The following is a description of a gene set: The presence of excess amniotic fluid in the uterus during pregnancy. Human Gene Set: HP_POLYHYDRAMNIOS studied in species Homo sapiens Polyhydramnios, and this is the list of marker genes: SNRPB, TRAIP, TBCD, TP63, KBTBD13, IBA57, VAC14, NRCAM, ADAT3, B3GLCT, COL13A1, HACD1, ERBB2, ZMPSTE24, LBR, SCN4A, SYNE1, MAMLD1, WNT3, TPM2, DIS3L2, EGFR, RPL10, SIN3A, ADARB1, KRAS, MAGEL2 (NCBI Gene Id 54551), CREBBP, CLCN7, RERE, ATP6V0A1, SLC5A7 (solute carrier family 5 member 7), DPM2, TBC1D24, NRTN, DYRK1A, SCYL2, GBA1, MYH11, ASCC1, KCNJ6, CHD7, COASY, SPRED2, NRAS (NRAS proto-oncogene, GTPase), ABCD1, RPL11, ALDH1A2, KDM3B, PIGN, MYO9A, MADD, SELENON, ACTA1, HSD17B4, UFD1, SLC35D1 (NCBI Gene Id 23169), HYLS1, CCDC47, SLC18A3, RAB34, CHRNA1, SCN8A, SLC27A4, TSEN2, PHACTR1, SHOC2, BUB3 (NCBI Gene Id 9184), MYH3, CRB2, PIGQ (phosphatidylinositol glycan anchor biosynthesis class Q), FIG4, TFAM, RREB1, GPC4, FUT8, PWAR1, HRAS, WBP4, TBCK, JMJD1C, ZC4H2, TRIP11, CRELD1, ITGB4, CLPB, INPPL1 (inositol polyphosphate phosphatase like 1), CDC42BPB, ARVCF, MTM1 (myotubularin 1), AKT2, FKBP14, SLC2A1 (solute carrier family 2 member 1), TMCO1, NPAP1, DPF2, AMMECR1, MTHFR, MDFIC, CHD8, RYR1, MYLK, ERBB3, TAPT1, COL2A1, ODC1, FGFR2, TRIP13, ESCO2, SLC25A26, PWRN1, EBP, PRMT7, DMPK, SOX17, NPHP3, AVPR2 (arginine vasopressin receptor 2), FGFR3, MAP2K2, IRF6, ASCL1, RET, MYOD1, PCGF2, RSPO2, SNAP25, YWHAE, MSX1, KIF7, CILK1, LMNA, TTC7A, BUB1, DOK7, DYNC2LI1, AGRN, FOXE1, SLC25A1, PPP1R13L, ADAMTS3, SMG9, MOGS, MTMR14, ATP7A, B3GALT6, GBE1, ATP1A2, RTL1 (NCBI Gene Id 651665), SLC25A46, ZBTB42, PTH1R, DYNC2I2, NEB, NPC2, SLC9A3, MUSK, CHRND, FANCB, CFL2, RHD, FLNB, LMOD3, SOD1, TSEN54, PI4KA, DLK1, ENPP1, KIF21A, ASXL1, MYCN, CBL, MAFB, ACTG2, SNORD115-1, TPM3, GLE1, BSND, HIRA, ZFX, PPP1CB, KLHL40, SKIC3, KIAA0586, GLDN, CDK13, BIN1, PIEZO1, NECTIN1, MEG3, CHRNG, VANGL2, SEMA3E, IPO8, CHAT, EDNRB, LONP1, ALG9, RMND1, VAMP1, OFD1, IFT56, RRAS2, ANO1, SLC16A2, HBA1, FANCF, SMO, SEMA3C, MKRN3, ABCC6, PAICS, ZNF699, SPINT2, KAT6B, HBA2, BRAF, DYNC2I1, PLEC, DNM2, MAGED2, PLAA, ERF, NUP88, EDN3, DPH5, GPC3, WDR81, ALPL (NCBI Gene Id 249), TBX1, HOXD13, PIGA (NCBI Gene Id 5277), SEMA3D, ATAD3A, SPOP, SLC26A3, AMER1, SLC12A1, DTYMK, BUB1B, ZIC3, PHGDH, INSR, ASXL3, HSPG2, RIT1, PRRX1, CLCNKA, ALG14, CD96, LZTR1, HIC1, STRADA, MYL2, ACTB, DHCR7, KCNJ1, SEC24C, ATP6V1B2, SZT2, ITGA6, OTX2, SOS1, LMOD1, OTUD5, PAFAH1B1, FOXF1, NALCN, MYPN, EXT2, TUBA1A, PSAT1, KLHL41, IKZF1, PIGY, GRM7, CNTNAP1, PRDM13, ADCY6, MYL1, SNORD116-1, BICD2, KMT2D, SREBF1, ALG12, SOX9, COL11A2 (collagen type XI alpha 2 chain), TNNC2, CLCNKB, WDR35, RAPSN, TRAPPC12, GDNF, TBX4, PHOX2B, KDM6A, AQP2, KIDINS220, CALCRL, FH, CNTN1, CSNK2A1, TRPV6, CEP57, EXTL3, ITGA7, COMT, SLC26A2, PLVAP, TWIST1, GP1BB, SYT2, RAF1, HERC2, FLVCR2, ECE1, MYF6, EP300, TOR1A, ADGRG6, SLC25A12, LTBP3, MAP3K20